Given this list of marker genes IL1B, NLRC4, CASP1, IL18, PYCARD, here is a description of the gene set: Pathway Definition from KEGG: (NLRC4+PYCARD) -> CASP1 -> (IL1B,IL18) Human Gene Set: KEGG_MEDICUS_REFERENCE_NLRC4_INFLAMMASOME_SIGNALING_PATHWAY species: Homo sapiens NLRC4 inflammasome signaling pathway. Pathway ID: N00867. Pathway type: Reference. Pathway class: nt06521 NLR signaling.